Given this list of marker genes Ggt7, Chac1, Chac2, Ggt5, Dpep1, Ggt1, here is a description of the gene set: Mouse Gene Set: GOBP_GLUTATHIONE_CATABOLIC_PROCESS The chemical reactions and pathways resulting in the breakdown of glutathione, the tripeptide glutamylcysteinylglycine, which acts as a coenzyme for some enzymes and as an antioxidant in the protection of sulfhydryl groups in enzymes and other proteins. studied in species Mus musculus